Given this list of marker genes DEFA3, DEFA5, DEFA1, DEFA1B, DEFA6, DEFA4, here is a description of the gene set: The disruption of a cellular component of another organism, leading to damage or temporary subversion of that structure. In some cases this can cause malfunctioning of the cells and death of the target organism. Human Gene Set: GOBP_DISRUPTION_OF_CELLULAR_ANATOMICAL_STRUCTURE_IN_ANOTHER_ORGANISM species: Homo sapiens